The following is a description of a gene set: Human Gene Set: HP_ABNORMAL_TARSAL_OSSIFICATION studied in species Homo sapiens An abnormality of the formation and mineralization of any of the tarsal bones, seven bones of the foot comprising the calcaneus, talus, cuboid, navicular, and the cuneiform bones. Abnormal tarsal ossification, and this is the list of marker genes: SLC35D1, PTH1R, CANT1, MATN3, HOXA13, EBP, COL2A1, EIF2AK3, INPPL1 (inositol polyphosphate phosphatase like 1)